Given this list of marker genes TGIF1, EIF2B5, HEPACAM, FGFR2, MYCN, TSC2 (TSC complex subunit 2), KRAS, PTEN, CRIPTO, STRADA, NPRL2, CRADD, GLI2, SMS, FOXH1, SHH, ZIC2, NODAL, GAS1, STIL, CCND2, SMO, FGF8, SIX3, TSC1, DISP1, MTOR, PTCH1, DEPDC5, NRAS, MLC1, PIK3CA, DLL1, PIK3R2, AKT3, CDON, IFNG, TBC1D7, FGFR3, HRAS, RAB39B, HERC1, NPRL3, ASPA, here is a description of the gene set: Megalencephaly Diffuse enlargement of the entire cerebral hemispheres leading to macrocephaly (with or without overlying cortical dysplasia). Human Gene Set: HP_MEGALENCEPHALY species: Homo sapiens